The following is a description of a gene set: Mouse Gene Set: MARTINEZ_RB1_AND_TP53_TARGETS_DN from publication Martínez-Cruz AB, Santos M, Lara MF, Segrelles C, Ruiz S, Moral M, Lorz C, García-Escudero R, Paramio JM (PMID 18245467) studied in species Mus musculus Genes down-regulated in mice with skin specific double knockout of both RB1 and TP53 by Cre-lox. Squamous cell carcinomas (SCC) represent the most aggressive type of nonmelanoma skin cancer. Although little is known about the causal alterations of SCCs, in organ-transplanted patients the E7 and E6 oncogenes of human papillomavirus, targeting the p53- and pRb-dependent pathways, have been widely involved. Here, we report the functional consequences of the simultaneous elimination of Trp53 and retinoblastoma (Rb) genes in epidermis using Cre-loxP system. Loss of p53, but not pRb, produces spontaneous tumor development, indicating that p53 is the predominant tumor suppressor acting in mouse epidermis. Although the simultaneous inactivation of pRb and p53 does not aggravate the phenotype observed in Rb-deficient epidermis in terms of proliferation and/or differentiation, spontaneous SCC development is severely accelerated in doubly deficient mice. The tumors are aggressive and undifferentiated and display a hair follicle origin. Detailed analysis indicates that the acceleration is mediated by premature activation of the epidermal growth factor receptor/Akt pathway, resulting in increased proliferation in normal and dysplastic hair follicles and augmented tumor angiogenesis. The molecular characteristics of this model provide valuable tools to understand epidermal tumor formation and may ultimately contribute to the development of therapies for the treatment of aggressive squamous cancer., and this is the list of marker genes: Yipf4, Cald1, Atf7ip2, Lyar, Rab6a, Meis2, Krt86, Plec, Ncoa5, Pcbp2, Vamp8, Xpo5, Krtap5-25, Krtap21-1, Fryl, Dop1b, Pam16, Grk4, Rps18, Mrpl39, Clpb, Gjb6, Eln, Enc1, Rps8, Mt2, Efna3 (NCBI Gene Id 99908), Fkbp5, Pttg1ip, Pinlyp (phospholipase A2 inhibitor and LY6/PLAUR domain containing), Krt83, Ndufaf7, Eif4ebp1, Mrpl33, Krt79, H2bc4, Ube3a, Calr, Bmerb1, Trh, Krt35, Tomm70a, Enox2, Ndufa5, Gnmt, Tnnc1, Notch1, Cx3cr1, Trbv29, Tg, Gprc5d, Rbbp6, Msh4, Rpl3l (ribosomal protein L3-like), Aars1, Ndufa2, Tjp2, Igfbp4, Adgrg1, Homer2, Krtap28-13, Elovl3, Zdhhc14, Myh6, Ovol1, Mga, Aurkc, Map3k5, Celf4, Ecrg4, Lpcat1, Sfrp2, Psors1c2, Fkbpl, Siva1, Eif3e, Sfxn3, Sox2, Iapp, Marcksl1, Hras, Sox11, Prelp, Ephx1, Calhm5, Ptpre (NCBI Gene Id 19267), Neo1, Ubc, Lig3, Mtf2, Slc44a1, S100a3, Spesp1, Rrad, Prss12, Fastkd2, Cd248 (NCBI Gene Id 70445), Camk2b, Pds5a, Pax6, Sap18, Clip4, Rarg, Chd4, Slc39a11, Pip, Galnt11, AI661453, Rasl11b, Myo10 (NCBI Gene Id 52514), Agfg2, Krtap4-2, Dstyk, Edaradd, Slc39a14, Xist, Myh3, Polr2l, Krtap9-22, Rpl27, Dct, Cacfd1, Riok3, Chac1, Clcn3, Lce1i, Hjurp, Mybl2, Ctnnbip1, Lgals7, Myh1, Sox5, Mup1, Krt85, Taok1, Smad1, Krtap19-4, Riok2, Incenp, Scmh1, Psmc4, Wdr12, Dnajc3, Pde3a, Tex261, Ptpn13, Upp1, Cyp17a1, Masp1, Krtap19-1, Acvr2b (NCBI Gene Id 75114), Bhlha15 (NCBI Gene Id 69111), Pkd1, Baalc, Purb, Basp1, Sdhaf4, Irx4, Man2b1 (mannosidase 2, alpha B1), Hoxa3, Npy, Mgat2, Maml1, Krtcap2, A030005K14Rik, Magohb, Lce1h, Usp18, Elovl6, Wnt5a, Ctnnal1, Fbln2, Cxxc5, Ccdc71, Krt75, Gsdma, Pgd, Numa1, Dpysl3 (NCBI Gene Id 22240), Krtap6-5, Lasp1 (LIM and SH3 protein 1), Hacd2, Bcr (BCR activator of RhoGEF and GTPase), Cops9, Hr, Lama2, Egr2, Retreg3, Rps21, Rhbdl3, G6pdx (glucose-6-phosphate dehydrogenase X-linked), Krtap12-1, Ncapd2, Ntn1, Ppib, Aqr, Ppih, Tceal6, Krt81, Rpn2, Dnajc17, Col1a1, Zfp36, Wfdc21, Krt36, Ptgds, Nfia, Rpl37, Aldh1a3, Srek1, Mki67, Atm, Car6, Gm42047, Cers4, Ppcdc, Prnp, Ank3, Snrpg, Shmt1, Dkk2, Poldip3, Pmel, Ctns, Pdap1, Rbbp8, Atp11a, Fubp1, St14, Rhou (ras homolog family member U), Slc27a4, Krtap9-3, Igfbp2, Kat7, Tia1 (cytotoxic granule-associated RNA binding protein 1), Krtap15-1, Rbbp4, Krt82, Mtrex, Edn3, Rhbg (Rhesus blood group-associated B glycoprotein), Krtap14 (NCBI Gene Id 23927), Rims2, Pank1, Ethe1, Myh14, Mrpl52, Nav2, Smad4, Usp19, Cyp2g1, Pabpn1, Strbp, Kpna6, Gclc, Dmd (dystrophin, muscular dystrophy), Rps6, Gabrp, Lsr, Mt4, Ypel1, Pdcd7, Acan, Mfap3, Krtap19-3, Ammecr1l, Son, Esrp1, Fbn2, Wwc1, Hmgcs1, Gtf2b, Nkd2, Mgll (NCBI Gene Id 57888), Cct6a, Adamts4, Mcl1, 5033421B08Rik, Ublcp1 (ubiquitin-like domain containing CTD phosphatase 1), Flna, Ube2f, Zmynd11, Tmed10 (transmembrane p24 trafficking protein 10), Krt32, Rpl23, Pmepa1, Gjb2, Sox9 (NCBI Gene Id 70015), Pigq, Brd2, Trip13, Tpo, Tnfrsf19, Cct2, Slc7a5, ENSMUSG00000125611, Sp110, Iffo2, Ptprf, Herc6, Idi1, Smarcd2, Krtap4-13, Gas1, Tmod2, Plxna2, Hopx, Cebpg (CCAAT/enhancer binding protein gamma), Tpr, Pom121, Agpat1, Hipk2, Csnk1d, Efnb1, Ints6l, Sephs2, Nfib, Ilf3, Spint1, Ltbp2, Dynlt1b (NCBI Gene Id 21648), Mis12, Cwh43, Tfdp1, Zscan26, Nhsl1 (NHS like 1), Dlk1, Kdm5b, Rbm6, Sf3b2, Pkig, Atp5if1, Msx2, Krt34, Vdr, Supt6, Krtap4-16, Kera, Ly6g6d, Max, Zcchc9, Egfr, H2bc22, Snx30, Wdr75, Atf1, Acsl5, Ppp4r3b (NCBI Gene Id 104674), Sh3rf1, Tnrc6a, Slc35a2, Krt71, Actc1, Rcc2, Cpsf4, Atp5pd, Plxnb3, Fads3, Shisa2, Npepl1, Krtap1-5, Pigu, Clu, Dlx1, Misp, Tecr, Rab12, Krtap6-7, Rhog, Fbp1, Safb2, Krt31, Bach2, Itpr3 (NCBI Gene Id 21779), Bach1, Srsf3, Lad1, Nectin2 (NCBI Gene Id 19294), Edc4, Capn6, Krtap3-1, Pou1f1, Ces4a, Hmgb1, Eprs1, Kif1c, Lgr5, Patz1, Stx18, Slc39a6, Grhl1, Zfp148, Sprr1a, Nherf2, Krtap6-3, Abce1, Krtap6-1, Krtap19-2, Snca, Ripk4, Krt33a, Aplp2, Sptbn2, Ero1a, Rpl34, Tnnt1, Siah1a, Cibar1 (NCBI Gene Id 68099), Rnaset2b, Plk1, Mrtfa, Huwe1, Aff2, Extl3, Naa12 (N(alpha)-acetyltransferase 12, NatA catalytic subunit), Neurod4, Zmym4, Set, Fgf7, Nr2f1, Glipr1l2, Rpl37a, Rrn3, Tgs1, Fzd7, Canx, Ssbp2, Gstp2, Kmt5a, Trim2, Prmt5, Mbd3l2 (NCBI Gene Id 234988), Hspa8, Rab4a, Ltbp1, Glo1, Ggt1, Diaph3, Slc5a6, Igdcc4, Crtc3 (NCBI Gene Id 70461), Hhip, 2510002D24Rik, Tle3, Cdk2ap1, Tro, Apba3, Rnf149, Errfi1, Srrm1, Cap1, Tfap2b, Ldhb, Marcks, Rbfox2, Dnph1, Krtap20-1, S100a14, Cpt1a, Krt72, Plcb1, Col6a2, C1d (C1D nuclear receptor co-repressor), Cxcl14 (C-X-C motif chemokine ligand 14), Lama5, Cdh3, Thra, Apoe, Fhdc1, Gip, Junb, Sntb2, Bicc1, Celsr2, Tardbp, 1700091H14Rik, Piwil2, Krtap6-2, Aldh3a1, Smo, Cryl1, Slc35b1, Col11a1, Tnmd, Lsm12 (NCBI Gene Id 68741), Ncdn, Foxc1, Krtap5-2, Col18a1, Ndufa3, Polr2a, Polg, Abca2, Ccnd2, Tmem131l, Ece1, Rps25, Ccnl1, Rpl26, Krtap19-5, Pfn2, Spon1, Bambi, Mt1, Prokr1, A030005L19Rik, Faap20, Dus1l, Ccdc137, Krt17, Aatf, Ccdc43 (coiled-coil domain containing 43), Pmfbp1, Krt33b, Rps7, Brd3 (bromodomain containing 3), Ints9, Pcolce, Ucp2, Gdpd3, Rtraf, Foxo1 (NCBI Gene Id 99758), Tenm4, Slc25a10, Rps17, Gm12617, Frmd4b, Nfe2l3, Col9a3, Ap4s1, Slc45a3 (NCBI Gene Id 98605), Krtap8-1, Padi3, Retnlb, Fzd6, Cdkn1a, Rhov, Polr3a, Krt25, Tmcc3 (transmembrane and coiled coil domains 3), Timmdc1, Krt27, Zfp574, Tenm2 (NCBI Gene Id 77515), Rtp4, App, Tnnt2, Arhgef25, Hook2, Epha5, Clec10a, Galr1, Peg3, Cryba4, Rilpl2 (Rab interacting lysosomal protein-like 2), Celf1, Cebpb, Timp3, Pkp2, Defb6, Hmga1, Man2c1, Hacd4, Mif4gd, Phb2, Scaf11, C1ra (NCBI Gene Id 50909), Rmnd5b, Ubl5, Clns1a, Qng1, Pigb, Crym, Ubqln4, Tnni1, Tchh, Ryr1, Cux1, Fa2h, Tcf20, Mta1, Rps24, Bbip1, Tor2a, Smarca4, Clk1, Sf3a2, Thrap3, Rdh10, Rdh11, Krtap16-3, Wrap73 (NCBI Gene Id 77155), Krtap13-1, Mbp, Ndel1, Gna13, Wrn, Ddr1, Atp6v0c, Crim1, Nme7, Ccnd1, Zfp280d, Atxn7l3b, Os9, Camkk2, Golga4, Cenpa, Tc2n, Pip5k1c, Impact, Krtap19-9b, Cdkn1c, Krtap9-1, Dlx3, Map4, Plod2, Rpl14, Scara3, Erc1, Unc5b, Klk10, Pde4dip, Pja1, Krt23, Fxyd4, Eftud2, Foxp1, Rassf3, Scyl1, Rpl21, Mllt1